Given this list of marker genes GHITM, EIF3A, RNF103-CHMP3, MCMDC2, NOTCH2, DNAJC6, DLGAP5, LPAR4, RAB8A (NCBI Gene Id 4218), FAM131B (NCBI Gene Id 9715), CILK1, DCDC2, MBTD1, ACVR2B, LCOR, RUNDC3B, RAB2A, ZNF528, TAF12, SKIDA1, PRKD3, WDHD1, MAPRE1, RDH11, SEZ6L, FGFR2, NAV1, GTF2E1, ITGA8, CELF1, PTGER4, STRN, POGK, GCSAML, TIMM23, ZSCAN29, EPC2, CEMIP2, MAGEB18, PIP4K2A, CNBP, GPR4, NKD1, FHAD1, CHMP3, CDK8, MEF2D, C11orf87, ZNF592, ITSN1, POU2F1, WNT3, CAB39, ZFAND5, TMEM242, DCX, PAQR8, PI15, COA5, SLC35A5, PLEKHG7, JADE1, TC2N, IKZF2, ZNHIT6, USP10, ASAH2B, CPEB2, PGAP1, DLG2, SEPTIN10, CMTM6, MYH1, TBC1D12, PIKFYVE, NTRK2, ILDR2, ATXN7, COPG2, CDH26, JARID2, KIF2A, PTBP3, OTULIN (NCBI Gene Id 90268), QKI, HIF1AN, SDAD1, ZNF677, LARP4 (NCBI Gene Id 113251), NFIA, TTN, CLCF1, FAM210A, GARIN1A, CREB5, USP1 (NCBI Gene Id 7398), ATAD2B, AFF4, VPS13B, TPT1 (tumor protein, translationally-controlled 1), SYN3, PDE3B, LRRC32, KDM7A, PRELID3B, ULK2, OGFRL1, FAM135B, APOL6, PITHD1, RNF38, IPO8, TUB, PLCL2, AFF2, PDS5B, RPP14, SCN8A, MLLT10, PRKAR1A, IL6R, ARPP21, GRM5, CCNF, DTD1 (NCBI Gene Id 92675), MAP4, PALB2, ALG9, USP44, TSPAN2, AP4E1, KLHL31, CERT1, CNNM2, TRUB1, PRDM2, ZFY, GATAD2B, PCNP, SYCP2, LIN7A, HDAC2, RPL32, SLC25A36, ELK4, C1orf21 (chromosome 1 open reading frame 21), SNAP25, ISL1, MLXIP, LPCAT3, SLC27A6, RHBDL2, AP3S1, MARCKS, EPN2, EOGT, PDE4B, ZSCAN30, DDX52, SPOPL, ZNF385B, CNOT6L, ZNF639, RTF1, ARPC5L, PTPN21, ANKRD30A, PTGDR, SLC39A2, CCN1, VPS13D, NHERF4, NXPE4, PRADC1, ZNF84, CR1, XIAP, UBE2Q2, BMPR1B, RAP2B, NGLY1, C18orf54, GSTA4, SLC26A2, SLC10A6, CASP10, NAA50, CCDC177, POLI (DNA polymerase iota), CREBZF (NCBI Gene Id 58487), ATXN7L3B, HARS2, GAB1, RNF144B, PIAS2, CASP9 (NCBI Gene Id 842), ZFYVE28, FGF12, LMCD1, PCDHB6, FPGT, TAB2, RAB3IP, OSTC, AUTS2, PGAM5, FAM181A, VKORC1L1, TERF2 (telomeric repeat binding factor 2), MPP1, SLC12A8, METTL9, CA4 (NCBI Gene Id 762), ENTPD1, ANKS4B, SPATS2, HAT1, RSL24D1, ZNF207, ZBTB1, INO80, SLTM, SNAP23, CCDC186, SOD2, FUT1, NEK9, PUM1, DUSP19, DENND4A, RWDD4, SLC25A5, ATP6V1G1, TENM1, MANSC1, ZNF154, BLOC1S3, UBASH3B, CSRNP1, here is a description of the gene set: Human Gene Set: MIR519D_5P from publication Chen Y, Wang X (PMID 31504780) Genes predicted to be targets of miRBase v22 microRNA hsa-miR-519d-5p in miRDB v6.0 with MirTarget v4 prediction scores > 80 (high confidence targets). species: Homo sapiens